Given this list of marker genes CEP19 (centrosomal protein 19), BRD4, DEPDC5, PODXL, PMS1, CSF1R, BBS12, TTPA, POLG, SLC19A3, CHD3, TMEM106B, DLAT, SLC25A36, TIAM1, TLR3, VAMP1, TGM1, GNB1, DZIP1L, COQ7 (NCBI Gene Id 51672), GON7, MT-TP, HSPG2 (heparan sulfate proteoglycan 2), MKKS, MSH6, TREX1, PIK3CA, PRKCG, SPRED1, ERF, MAB21L1, ABCB7, CRIPTO (NCBI Gene Id 6997), SZT2, ASL, SLC9A7, PI4KA, KCNC3, CDK8, RFX7, ARVCF, TP53RK, HDAC8, CREBBP, MED13, BBS1, CSTB, HNRNPH2, BRCA2, DRD4, KCNT1, ZFYVE26, TANC2, PLAU, ATP6V1A, SIN3B, SLC12A5, HSD17B10, GRIA4, HNRNPA2B1, NEFL, GJB2, ATP1A2 (NCBI Gene Id 93186), PEX19, ECM1, CCR1, EIF4H, HEPACAM, CDKN2B, CNKSR2, SUMF1, SCN1B, LIG4, IFT172, SEC23B, NPHP1, SOX6, CRH, IGF2, SNRPN, EPM2A, PEX11B, DSG4, KRT81, GPC4, HNRNPC, FGF14, PRNP, PFN1, AUH, DNAJC21, TUBA1A, PPP2R2B, SDR9C7 (short chain dehydrogenase/reductase family 9C member 7), MT-CO1 (NCBI Gene Id 4512), SLC22A5, PEX26, ATP6V0A2, FANCD2, FGF8, SH2B1, MT-TV, DAOA, TLK2 (NCBI Gene Id 11011), ERCC6, CEP152, ZMYM2, FERRY3, NOTCH3, PARK7, RNU4ATAC, CDH2, TPRKB, DMD, UBTF, SUPT16H (NCBI Gene Id 6831), RBBP8, SCARB2, TRANK1, SNCAIP, ALDH18A1, ROGDI, SDHC, FGFR1, PAH, MT-ND1, ALKBH8, LIMK1, TOMM40, SLC25A13, KCNB1, SEC24C, ARPC4, TYROBP, ITM2B, CHI3L1, EIF2B2 (eukaryotic translation initiation factor 2B subunit beta), AARS2, MTFMT, PHF21A, EIF2B1, FOXH1, NKX2-1, CACNA1C, PRKRA, GMPPB, SATB1, TTR, NCF1, TSPOAP1, FBXO28, PRR12, BBS4, PIDD1, EFL1, PPP3CA, GLI2, MRPL39, DCC, GABBR2, TBCK, KCNA2, SLC1A2, GNA11, FKTN, ATP6V0A1, PRDX1, CHRNA4, USP48, SNORD115-1, MT-RNR1 (mitochondrially encoded 12S rRNA), PDE11A, PCGF2, DNM1, PEX2, FUCA1 (alpha-L-fucosidase 1), PTCH1, MT-CYB, OPA3, TRAF7, MYT1L, GALC, FGF12, NUP85, LGI3, BSCL2, SLC6A8, DNMT1, MT-ATP6 (NCBI Gene Id 4508), EIF4A2, LTBP4, SLF2, TBP, CHRNB2, MT-ND6, CISD2, ADNP, ARL6, COASY, SLC44A1, UBAP2L, CRBN, UCHL1, BAP1, RNASEH1, HERC2, ANAPC1, SOX5, TLR4, RBM12, MSH2, GTF2I, HCN1, STX1A, ZFX, MEN1, CLIP2, ZIC2, TRAIP, LIPN, IGF1, CLN6, ADH5, GNAQ, SDHB, CFAP410, ANG, GP1BB, UBE3A (NCBI Gene Id 7337), LARGE1, TBC1D24, NIPBL, TBL2, NFIB, GDAP2, DISP1, SCLT1, NIPA1, SMARCA2, PLCB1, SULT2B1, MFSD8, TUBB4A, COG2, MAPK1, CYFIP2, GRIK2, SUFU, TRPM7, SOD1, ADD3, FTL, KCNH5, GBE1, ADGRL1, HNRNPK, IFNG, DCX (NCBI Gene Id 1641), ADAMTS13, SLC38A3, GSN, TREM2 (triggering receptor expressed on myeloid cells 2), FBXO11, SLC13A3, CHRNA7, SDHAF1, CTCF, GLRX5, DAO, TSC1, TWNK, PABPN1, YRDC (yrdC N6-threonylcarbamoyltransferase domain containing), APC2, MAN2B1, PEX3, HLA-B, MKS1, PANK2, GJC2, CASP2, TTC19, PRKD1, JARID2, DNAJC30, CDKN1A, SMO, FOXG1, SAT1, PCDH19, SRCAP, CP, DGUOK, GABRG2, LAMA1, KIF11, SDHD, CSGALNACT1, POMGNT1, NUP107, NIPAL4 (NIPA like domain containing 4), ATRX (ATRX chromatin remodeler), CHD5, GNPTAB, DARS2, AKT1, IL12A (NCBI Gene Id 3592), RYR1, JRK, UBAP1, SNORD118, NTRK2, GALK1, ERCC4, B3GALNT2, USP7, CENPE, SLC7A7, SUCLG1, SCN1A, FANCL, CFAP418, MMACHC, IL10, FBN1, DYRK1A, PACS2, ZMIZ1, CDK19, PDE10A, SLC25A4, CAMTA1, VPS13A, MED12, PKHD1, LYST, CYC1, SERPINI1, SQSTM1, NR4A2, SIN3A, GABRB3, PLK4, SIX3, DMPK, OPA1, MME, ACTB, TBX2, SLC2A1, PSMB1, LARS2, GLUD1, CUX2, NR3C1, DRD5, JPH3, UBE4A, NODAL, HNRNPA1, TFE3, DNAJC12, NAA60, DPH2, NF1, KARS1, HIRA, FRRS1L, GLA, PTCHD1, CDON, CERS1, PHOX2B, ASCC3, TARDBP, KCND3, PIGA (NCBI Gene Id 5277), NAA15, ATXN2, SHH, SHMT2, POMT1, PEX14, SCN3A, RPS20, SLC37A4, SMC1A, SMPD1, OPHN1, ITPR1, IBA57, IDUA, AMACR, SGPL1, COX6B1, SLC25A22, CTSD, CUBN, UQCRH, MT-TK, XPA, ODC1, NPRL3, PPP1R21, HMGA2, NOS3, FKRP, CPT1C, NDP, MT-TL1, ALS2, XPC, PRICKLE1, UGT1A1, ALMS1, GCDH, C4A, MFN2, ATP7B (ATPase copper transporting beta), PINK1, TRAPPC14, ADAMTSL4, SLC18A2, DCTN1, CYP4F22, SYNJ1, MAPK10, CST3, SIGMAR1, KRT83, CNTNAP2, UNC13A, WDR45, TMCO1, LIG3, MYD88, KCNA4, XRCC4, MTOR, SLC7A6OS, PNKP, GNAS, APP, HNF4A, KCNQ2, CACNA1G, PPT1, MBTPS2, HLA-DRB1, AP3B2, NKX6-2, OPTN, GTF2IRD1, RAD21, HTRA1, NF2, SRPK3, PSAP, KMT5B, ADA2, KRIT1, SAMD9L, VCP, PAK3, NIPA2, SMARCB1, CABP4, TTC8 (tetratricopeptide repeat domain 8), NEFH, TBK1, STAG2, LAGE3, GBA1, KCNC1, DDB1, ALAD, AGK, PTRHD1, IDS, CPOX, PEX12, STARD7, PEX13, LAMA2, MAOA, LAMP2, VPS37A, RAB39B, AGO1, RSRC1, PON2, IKBKG, TNPO2, MAGEL2, CTSH, AP2M1, PON1, EBF3, JMJD1C, ERCC2, TIMM8A, BRAF, PPP2CA, LBX1, NDUFA1, COMT, TBX1, SRRM2, MICOS13, KIF1C, MT-TQ, RNU4-2, SECISBP2, SEMA3E, BBS5, GABRA1, CYP27A1, SCN9A, TMEM240, SPP1, GRID2, CEP290, ASPM, ERAP1, MED12L, ATM, TERT, SPTBN1, ATXN3, BCR, CARS2, SPEN, PMPCA, HMBS, YME1L1, GDF6, MKRN3, ZDHHC9 (zinc finger DHHC-type palmitoyltransferase 9), IRF6, C9orf72, GRIN2A, PDGFB, LMAN2L, POLG2, KAT5, EIF4G1, POU4F1, NKAP, TNIK, CLMP, ABCA7 (ATP binding cassette subfamily A member 7), CACNA1B, REEP2, CHRNA2, UBAC2, QDPR, GRIA1, FAS, WFS1, ALOX12B, MT-ATP8 (NCBI Gene Id 4509), GNB5, WDR73, PDGFRB, MT-CO2, CYLD, TAF15, DNAJC5, COL4A1, MPV17, CRLF1, NUS1, CLCF1, COA3, MARS2, NSUN6, ATP10A, CDKN2C, GM2A, KMT2A, CORO1A, PLA2G6, APOL4, PHIP, SPR, ATRIP, FOCAD, SPTLC1, PLAG1, ATN1, SOBP, UFD1, PWAR1 (NCBI Gene Id 8122), BMPR1A (NCBI Gene Id 8035), ABCA12, LZTFL1, SORL1, EHMT1, FGFR3, PTEN, RRM2B, EMC10, VPS13C, ASAH1, STX1B, HEXB, SLC6A1, MTRFR, SYN2, FIG4, C19orf12, TSFM, PTPN22, CC2D1A, WAC, PMS2, ZNF365, PSEN2, TRIM32 (tripartite motif containing 32), P2RY11, ABCA5, STS, VAPB, FLG, PARS2, DRD3, OSGEP, RMRP (NCBI Gene Id 6023), ADH1C, ACSF3 (NCBI Gene Id 197322), JAM2, LHCGR, TSHB, PORCN, OCRL, FLNA, HIBCH, MT-TW, NAGS, TUBB3, PRKAR1A, MT-TF, ATP9A, TUBB2B, RBM28, KDM4B, KPNA3, ATP1A3, ERCC5, RTN4R, RNF216, GRIN2D, DHDDS, DDB2, SEMA4A, CELF2, AIFM1, H4C5, STUB1, KRAS, IQSEC2, LRPPRC, GABRA2, SCN2A, NOP56, AGO2, MT-TC, SETD5, BBS9, HEXA, ATP6V1E1, DNAJC13, CARS1, IL12A-AS1, NAT8L, FA2H, AUTS2 (NCBI Gene Id 26053), ROBO3, PRDM8, HOXA2, FMR1, ATP13A2, FTH1 (NCBI Gene Id 92182), GDF5, COQ4, GDF3, PEX5, MATR3, CDH23, GCH1, NPAP1, EIF2B5, BDNF, ABCD1, YY1, TAF1, NR2F1, ARSA, SPART, TMEM67 (NCBI Gene Id 91147), PEX10, SDCCAG8, GBA2, IFT27, HCRT, CFHR3 (complement factor H related 3), HTT, MT-TT, CACNA2D1, TINF2, PURA, UPF3B, CHRNG, MOG, FUS (FUS RNA binding protein), YWHAG, GALT, MEFV, TNFSF4, CHRM3, APTX, MPO, CHCHD10, HADH, POLE, CDKN1C, CTDP1, MECP2, IVD, CRKL, DNAJC6, MADD, MT-TE, GLB1, TUBA4A, PIEZO2, CTSF, KRT86, PDCD10, NAGA, TSC2, DCDC2, APOL2, SPTAN1, ATXN8OS, GOSR2, SLITRK1, PLEKHG4, RFC2, MT-CO3, PRKN, TRIO, STAT4, TAF6, MAG, APOE, ZNF292, PNPT1, MBD5, SLC2A3, GTF2IRD2, SYNE1, CCNF, CLTC, CCM2, AFG3L2, SMARCE1 (NCBI Gene Id 6605), SLC1A3, MID1, PDZD8, PRRT2, MEOX1, GRN, SPG11, OTC, DPH1, PLP1, BBS10, EPCAM, KMT2B (NCBI Gene Id 9757), PON3, GLT8D1, NFIA, STEEP1, SH3KBP1, KLLN, EIF2AK1, PRPH, CTNS, NHLRC1, CHEK2, KANSL1, FLII, PSEN1, COQ5, KCNN2, ERCC3, PPM1D, TKT, SPG21 (SPG21 abhydrolase domain containing, maspardin), KDM3B, HDAC4, TNRC6B, LRRK2, HDC, EDN3, DNM1L, SPG7, ASPRV1, NBEA, SMC5, MLXIPL, CAPRIN1, NUP133, WWOX, SATB2, IRAK1, SRPX2, SBDS, MYORG, GABRD, SETD1A, PUS7, BAZ1B, HTR2A, AASS, ALG13, GPRC5B, RIC1, PEX16, GLE1, MT-TS2, GIGYF2, AARS1, CHMP2B, PRKAR1B, DNAJC3, FZR1, CBL, NBN, GABRB2, FOXP2, KCNC2 (potassium voltage-gated channel subfamily C member 2), SHOC2, POLD1, WBP11, CMPK2, HTRA2, ANKRD11, CDKN1B, NPC2, ADGRV1, MCTP2, GATA4, FOXP1, RAB27A, SNORD116-1, SKIC3, BBS2 (NCBI Gene Id 583), GAS1, SPAST, NSUN2, ERBB4, UBQLN2, CIC, CNBP, ATR, SPTBN2, MUTYH (NCBI Gene Id 4595), CDC42BPB, RREB1, DYNC1I2, MT-ND4, L1CAM, VPS35, AP5Z1, EEF1A2, AHCY, MCOLN1, LMNB1, PCNT (pericentrin), CFHR1, SCO2, SCAPER, ERCC8, ANKRD17, TGIF1, METTL5, MAPT, RIN2, USP8, PEX1, ARL6IP6, FGD1, TRAK1, TIMMDC1, SETBP1, BCORL1, ZMYM3, MT-ND5, CSNK2A1, CACNA1H, TUBG1, GABBR1, TMEM270, DALRD3, SLC25A15, WDR4, CYP2U1, PLAA, TIA1, IL23R, NEK1, TK2 (thymidine kinase 2), NSD1, HLA-DQB1, STIL, ALDH4A1, KIF14, BUD23, POLA1, MLH1, MAP1B (NCBI Gene Id 4131), PRORP, CHD7, VPS37D (NCBI Gene Id 171020), FLI1, HGSNAT, TGFBR2, TYMP, SYNGAP1, NRAS, CFH, DYM, POLR3A, UBA1, DLG3 (discs large MAGUK scaffold protein 3), TP53, ANXA11, POGZ, SNCA, SIM1, KLRC4, KDM1A, HNRNPR (NCBI Gene Id 10236), FBXO7, COL3A1, SLC6A19, ARMC5, NEXMIF, METTL27, MYH3, PPP1R12A, THRB, PNPLA6, POLR3K, CLN5, SCN8A, PPARGC1A, NAGLU, CHD2, RERE, EP300, DHTKD1, IFNGR1, NECAP1, NPTX1, KCNQ3, NOTCH2NLC, GABRA5, ZBTB20, CDH11, MYO1H, DHCR7, GNE, UBA5, FKBP6, BBIP1, WDPCP, SNCB, MAP2K1, CTC1, TAOK1, DLL1 (NCBI Gene Id 28514), PLCH1, BBS7, NPC1, CFAP43, CRPPA, PWRN1, SMC3, ATXN10, XPR1, PRMT7, BCKDK, MTHFR, NPRL2, TMEM163, PTS, CLN8, NDUFA6, SLC20A2, FGF13, PEX6, CYP7B1, SDHA, ACTL6B, RAI1, SOST, POMT2 (protein O-mannosyltransferase 2), COQ2, TBC1D23, SLC13A5, USF3, TET3 (tet methylcytosine dioxygenase 3), NLGN1, SLC39A14, OCA2, ATXN1, TPH2, IFT74, ARID2, ALOXE3, ATXN7, GTPBP3, MT-TH, KIF5A, NTRK1, KCTD7, GDNF, DNA2, IQSEC1, CHD8, TBL1X, CACNA1A, CHCHD2, KAT8, DEAF1, ELN, CLN3, here is a description of the gene set: Abnormal cognition is characterized by deficits in thinking, reasoning, or remembering. Cognitive impairment Human Gene Set: HP_COGNITIVE_IMPAIRMENT species: Homo sapiens